The following is a description of a gene set: Mouse Gene Set: GOBP_POSITIVE_REGULATION_OF_HORMONE_SECRETION species: Mus musculus Any process that activates or increases the frequency, rate or extent of the regulated release of a hormone from a cell., and this is the list of marker genes: Edn3, Gpr39, Trpm5, Cyp2j5, Glud1 (glutamate dehydrogenase 1), Edn1, Stim1, Sirt1, Vdr, Snx4, Anxa7, Gnaq, Pfkfb2, Runx1, Hnf1a, Gprc6a, Irs2, Nlgn2 (neuroligin 2), Ppard, Spp1, Lrrc8a, Glp1r, Pck2, Cckbr, Rph3al, Vamp8, Slc30a8, Oxct1, Abat, Hcfc1, Ghrl, Itpr1, Aacs, Cckar, Myrip, Ucn3, Myb, Pdx1, Jak2, Gpld1, Tac1, Vsnl1, Cacna1d, Snap25, F2rl2, Gpr27, Rac1, Gna11, Smad4, F2, Prkar1a, Nr1h4, Nadk, Sybu, Kiss1r, Tcf7l2, Lep, Galr1, Tacr1, Ptbp1, Orai1, Nppa, Egfr, Gnas, Selenot, Pla2g3, Gper1, Creb1, Kiss1, Ffar2, Ecrg4, Aimp1, Ano1, Kif5b, Mlxipl, Prkaca, Mfn2, Sox4, Gip (gastric inhibitory polypeptide), Cntf, Prkn, Itsn1, Chrm3, Edn2, Pparg, Retn, Tardbp, Mpc2 (mitochondrial pyruvate carrier 2), Inhbb, Lif, Bad, Ucn, Oga, Arrb1, Nnat, Gja1, Fga, Nucb2, Agt, Fgfr4, Cask, Fto, Trpc1, Ptpn11, Cftr, Ptger4, Sox11, Gipr, C2cd2l, Trpm2, Nkx3-1 (NCBI Gene Id 18095), Slc2a2, Foxl2, Hif1a, Gpr68, Hfe, Nr0b2, Crh, Ghrhr, Osbp, Cyp27b1, Pfkm, Cacna1c (NCBI Gene Id 619317), Apln, Nmb, Stx4a, Casr (calcium-sensing receptor), Gcg, Rapgef4, Nkx6-1, Acsl4, Sct, Atg7, Rasl10b, C1qtnf1, Mcu, Drd2, Ffar1, Fgb, Acvr2a, Clcf1, Ppp3cb, Abcg1, C1qtnf12, Trpa1, Tm7sf3, Nell2, Doc2b, Gal, Blk, Cd38, Prkd1, Ildr1, Rab8b, Lepr, Ghrh, Tfr2, Camk2n1, Prkce, Rbp4, Serp1, Tmf1, Lrp1, Glul, Adcy8, Pla2g6, Gck, Trh, Tnfsf11, Ffar4, Plcb1, Gabbr1, Fgg, Grp, Isl1, Trpm4, Bglap2, Pex5l, Sirt6, Psmd9, Fgfr1, Abcc8, Myh9, Bmp6, Capn10, P2ry1, Hcar2, Irs1, Tunar, Baiap3, Dynll1, Rfx6, Arhgef7, Adcyap1, Ncoa6, Prkcb, C1qtnf3, Cyp19a1, Sirt3, Nmu, Dab2